Given this list of marker genes PDGFA, PDGFRA, ITGB1, SNAI1, CDH1, GJB6, FZD1 (frizzled class receptor 1), TP63, NFKB1, MYC, PTCH1, FOXI3, RUNX2 (NCBI Gene Id 860), CCND2, LEF1, GLI1, WNT5A, FGFR2, SMO, LAMA5, CTNNB1, BMP4, FGF1, GLI2, CCND1, INHBA, EDA, EDAR, LRP5 (NCBI Gene Id 8058), SHH, NCAM1, GTPBP4, here is a description of the gene set: Hair follicle development: organogenesis - stage 2 of 3 Human Gene Set: WP_HAIR_FOLLICLE_DEVELOPMENT_ORGANOGENESIS_STAGE_2_OF_3 species: Homo sapiens